Given this list of marker genes SASH3, RAC2, ALG12, SEC61A1 (SEC61 translocon subunit alpha 1), RNF31, BTK, here is a description of the gene set: species: Homo sapiens Human Gene Set: HP_DECREASED_SPECIFIC_ANTIBODY_RESPONSE_TO_PROTEIN_CONJUGATED_POLYSACCHARIDE_VACCINE Decreased specific antibody response to protein-conjugated polysaccharide vaccine A reduced ability to synthesize postvaccination antibodies against protein-conjugated polysaccharides in vaccines, as measured by antibody titer determination following vaccination.